Given this list of marker genes SUFU, PTCH1 (NCBI Gene Id 8015), PSENEN, PTCH2, POFUT1, KRT5, CIB1, POGLUT1 (NCBI Gene Id 56983), ATP2A2, here is a description of the gene set: Palmar pits studied in species Homo sapiens Human Gene Set: HP_PALMAR_PITS